Given this list of marker genes Serpina5, Gfra2, Ugt1a9, Cep104, Mthfsl, Pgd, Fabp6, Sell, Crabp1, Siglece, Slc19a1, Glra2, Acox2, Dmgdh, Apoc1, Sesn3, Dbt, Pitpna, Akr1c20, Nos3, Rbp2, Crabp2, P4ha3, Grin2b, Fabp4, Gldc, Id3, Sardh, Plod1, Folr2, P3h2, Acox3, Ptgds, Napepld, Hnf4a, Vdr, Slc1a1, Nr1h4, Adh5, Hlcs, Scp2, Fabp1, Thnsl2, Sesn1, Cyp4a14 (cytochrome P450, family 4, subfamily a, polypeptide 14), Cps1, Cyp4f15, Glud1, Ugt1a7c, Slc46a1, Fabp3, Tmem175, Pck1, Ubr1, Ugt1a2, Ugt1a10, Nr2f2, Fabp2, Gsta13, Shmt1, Cyp26b1, Plod2, Fabp9, Sh3glb1, Akr1c18, Akr1c19, Cyp4f14, Epdr1, Col11a1, Fabp12, Siglech, Plod3, Ogfod1, Hmbs, Gstp-ps, Glra1, Psap, Dhfr, Acoxl, Cd36, Igf2r, Ffar1, Nme2, Grin2a, Slc7a6, Glul, Egln1, P4ha2, Acox1, Tnfrsf11b, Ugt1a8, Grik1, Akr1c6, Ogfod2 (NCBI Gene Id 74767), Akr1c12, P3h3, Acaca, Ppia, Gstp1, Siglecf, Dbh, Akr1cl, Ubr2 (NCBI Gene Id 99387), Gsta5, Rbp7, Sesn2, Folr1, Gstm7, P3h1, Dmbt1 (NCBI Gene Id 270001), Pparg, Gsta2, Castor1, Acacb, Ftcd, Rxra, Glrb, Ugt1a1, Cd22, Akr1c13, Tm4sf5, Aldh5a1, Hmgcl, Adipoq, Uros, P4ha1, Izumo1r, Alb, Dgat1, Mthfs, Ptn, Siglecg, Egln3, Pla2g1b, Tyms, Cyp2w1, Grin3a, Phyh, Prr7, Ucp1, Got2, Akr1c21, Gstp2, Grin1, Grm7, Nrtn, Akr1c14, Grin2d, Cyp26a1, Got1, Slc1a3, L1cam, Cyp4f40, Lcn12, Gnmt, Furin, Pam, Hmgcs1, Rara, Gss, Ogfod3, Ryr2, Pygl, Cd33, Rars1, P2rx1, Selp, Gclc, Nod2, Hif1an, Ffar4, Gpr143, Lrat, Gstp3, Gpr31b, Rida, Cyp26c1, Insr, Hba-a1, Snca, Slc6a6, Rtn4r, Nos2, Alox5ap, Mtr, Gsta1, Fabp5, Stx3, Fcnb, Mag, Glra4, Slc38a9, Srr, Gad2, Pmp2, Pcx, Arhgdia, Yars2, Agrn, Rbp1, Glra3, Grhpr, Ppard, Sele, Siglecl2, Egln2 (egl-9 family hypoxia-inducible factor 2), P2rx2, Gad1, Mdk, P4htm, Fabp7, Grin3b, here is a description of the gene set: Mouse Gene Set: GOMF_ORGANIC_ACID_BINDING studied in species Mus musculus Binding to an organic acid, any acidic compound containing carbon in covalent linkage.